Given this list of marker genes TRNAU1AP (tRNA selenocysteine 1 associated protein 1), SELENOT, SECISBP2, SEPSECS, EIF4A3, SARS1, EEFSEC, DIO2, here is a description of the gene set: species: Homo sapiens The continuation of translation beyond a stop codon by the use of a special tRNA that recognizes the UAG and UGA codons as modified amino acids, rather than as termination codons. Human Gene Set: GOBP_TRANSLATIONAL_READTHROUGH